The following is a description of a gene set: The process in which an oligopeptide is transported across a membrane. Oligopeptides are molecules that contain a small number (2 to 20) of amino-acid residues connected by peptide linkages. species: Mus musculus Mouse Gene Set: GOBP_OLIGOPEPTIDE_TRANSMEMBRANE_TRANSPORT, and this is the list of marker genes: Slc15a4, Slco3a1, Slc26a6, Abcb10, Slco1b2, Mfsd1, Car2, Slc25a39, Slc25a40, Slc15a2, Abcc5, Slc15a3, Abcc1, Abcc4, Abcb9, Slc13a3, Gja1, Slc15a1, Slc7a11